The following is a description of a gene set: species: Mus musculus Mouse Gene Set: GOBP_NEGATIVE_REGULATION_OF_PROTEIN_POLYUBIQUITINATION Any process that stops, prevents or reduces the frequency, rate or extent of protein polyubiquitination., and this is the list of marker genes: Trim44, Ppia, Cep63, Parp10, Dysf, Gps2, Plaa, Ttc36